The following is a description of a gene set: Human Gene Set: BAKKER_FOXO3_TARGETS_UP Genes up-regulated in I/11 erythroblast cells upon expression of an activated form of FOXO3. The cooperation of stem cell factor (SCF) and erythropoietin (Epo) is required to induce renewal divisions in erythroid progenitors, whereas differentiation to mature erythrocytes requires the presence of Epo only. Epo and SCF activate common signaling pathways such as the activation of protein kinase B (PKB) and the subsequent phosphorylation and inactivation of Foxo3a. In contrast, only Epo activates Stat5. Both Foxo3a and Stat5 promote erythroid differentiation. To understand the interplay of SCF and Epo in maintaining the balance between renewal and differentiation during erythroid development, we investigated differential Foxo3a target regulation by Epo and SCF. Expression profiling revealed that a subset of Foxo3a targets was not inhibited but was activated by Epo. One of these genes was Cited2. Transcriptional control of Epo/Foxo3a-induced Cited2 was studied and compared with that of the Epo-repressed Foxo3a target Btg1. We show that in response to Epo, the allegedly growth-inhibitory factor Foxo3a associates with the allegedly growth-stimulatory factor Stat5 in the nucleus, which is required for Epo-induced Cited2 expression. In contrast, Btg1 expression is controlled by the cooperation of Foxo3a with cyclic AMP- and Jun kinase-dependent Creb family members. Thus, Foxo3a not only is an effector of PKB but also integrates distinct signals to regulate gene expression in erythropoiesis. from publication Bakker WJ, van Dijk TB, Parren-van Amelsvoort M, Kolbus A, Yamamoto K, Steinlein P, Verhaak RG, Mak TW, Beug H, Löwenberg B, von Lindern M (PMID 17353275) studied in species Mus musculus, and this is the list of marker genes: UNCX, GNAI2, TCP11L2, CHIC1, PINK1, SESN1, CPEB4, ZUP1, CPT1A, DCP1A, HIPK1 (NCBI Gene Id 23323), ULK1, NQO2, ARG1, RBL2 (RB transcriptional corepressor like 2), BTG1, C5orf63, CR2, KIT, ZNF780A, CCNG2, CITED2, DCN, DENND5B, P2RY14, GUCD1, SLC12A6, GRIA3, KLF6, ATP7A, NKIRAS2, TMX1 (NCBI Gene Id 81542), VCL, XPO7, DSTN, CCPG1 (cell cycle progression 1, NCBI Gene Id 9236), DNAJC12, NF2, SIRPA, ASAH1, PNPLA6 (NCBI Gene Id 10908), PGM2L1, RGS2, C5orf34, PGGT1B, HSCB, OSBPL9, CDKN1B, AMPD2, CSF2RB, SFT2D2, TP53INP1, PIK3IP1, VOPP1, CTSE